Given this list of marker genes Pygm, Phkg2, Calm1, here is a description of the gene set: part of: Glycogen metabolism Reactome Pathway: Glycogen breakdown (glycogenolysis) studied in species Mus musculus This event has been computationally inferred from an event that has been demonstrated in another species.<p>The inference is based on the homology mapping from PANTHER. Briefly, reactions for which all involved PhysicalEntities (in input, output and catalyst) have a mapped orthologue/paralogue (for complexes at least 75% of components must have a mapping) are inferred to the other species. electronically inferred by orthology from the curated human pathway